The following is a description of a gene set: Mouse Gene Set: GOBP_OSTEOBLAST_FATE_COMMITMENT The commitment of mesenchymal cells to the specific cell fate of an osteoblast. An osteoblast is a bone-forming cell which secretes an extracellular matrix. Hydroxyapatite crystals are then deposited into the matrix to form bone. species: Mus musculus, and this is the list of marker genes: Smad5, Runx2, Notch1, Men1, Sh3pxd2b, Smad1